The following is a description of a gene set: part of: Integration of energy metabolism Reactome Pathway: Insulin effects increased synthesis of Xylulose-5-Phosphate species: Homo sapiens One of the downstream effects of insulin, mediated via protein phosphatase 2A (PP2A), is increased synthesis of Fructose-2,6-bisphosphate, an allosteric activator of phosphofructokinase 1 (PFK1). PFK1 in turn catalyzes the committed step of glycolysis so the net effect of this whole sequence of events set off by insulin is to increase cytosolic concentrations of the small molecules formed in the course of glycolysis. This in turn drives the increased synthesis of Xylulose-5-phosphate, itself a positive regulator of PP2A., and this is the list of marker genes: TALDO1, TKT (transketolase)